The following is a description of a gene set: Mouse Gene Set: MIR_7082_3P from publication Chen Y, Wang X (PMID 31504780) Genes predicted to be targets of miRBase v22 microRNA mmu_miR_7082_3p in miRDB v6.0 with MirTarget v4 prediction scores > 80 (high confidence targets). studied in species Mus musculus, and this is the list of marker genes: Larp1, Maco1, Zfp148, Pias4, Set, Ppp4r2, Fxr2, Irx1, Pde4dip, Tenm4, Bag3, Zfp385a, Tnpo1, Prkar2b, Lmnb1, Gria1, Palmd, Stc2, Fam107b, Aplnr, Tnpo2